Given this list of marker genes SLC5A7, TRPV4, SCN4A, SLC25A1, SLC52A3, SOX9, NFASC, IGHMBP2, GBA1, LYRM4, COL13A1, MIR140, SCO2, NFIX, VRK1, EXOSC9, SCARF2, AGRN, PLP1, GNB1, DST, SERPING1, CHAT, MYO9A, EXOSC8, CACNA1C, SLC25A46, JAG1, GTPBP3, AGTPBP1, LAMB3, SLC18A2, LAMA3, MAP3K7, LAMC2, COQ2, EXOSC3, FLNA, PAX8, VPS33A, SNAP25, SLC18A3, GNPTAB, SYT2 (NCBI Gene Id 6858), TSPYL1, D2HGDH, VAMP1, CTSK, KIF22, MID1, here is a description of the gene set: species: Homo sapiens Human Gene Set: HP_STRIDOR Stridor Stridor is a high pitched sound resulting from turbulent air flow in the upper airway.